Given this list of marker genes FBXO3, GPT2 (NCBI Gene Id 84706), SLFN12L, PIGN, INO80 (INO80 complex ATPase subunit), CHST15, ERCC6L2, CHORDC1, ZBTB21 (zinc finger and BTB domain containing 21), PCGF5, LACC1, ATP8B4, SATB1 (SATB homeobox 1), PHLDA3, PPP4R3B (NCBI Gene Id 57223), IL34, ODR4, NLK, SMARCA5, C5orf63, B3GNT2, C1orf74, ZXDB, EPS15L1, UBE2T, OXNAD1, PMS1, TMEM41B, CD69, CEBPB, SLC19A2, OSGEPL1, TMEM62, ZFAND3, TRMT10A, CRTAM, ZFP62, KCNQ5, REV3L, CKLF, RGS3, KLHDC2, ULK2, NOL8, TGIF2 (NCBI Gene Id 60436), GINM1 (NCBI Gene Id 116254), OGFOD1, MYH7, CEP162, AEN, SYNJ2, RBBP8, IL15RA, BDP1, CRABP2, SNAPC1, RNF19A, CEBPZOS, RPRD2, LANCL3, CCNG1, PURB, QRICH1, ITIH4, TIMM17B, SOS2, EEA1, MFSD6, ZNF426 (NCBI Gene Id 79088), IFNG, GTF3C6, MFF (NCBI Gene Id 56947), NFKBIE, NSUN6 (NCBI Gene Id 221078), UTP20, RBPMS2, ITIH3, CDKN1A, CCSER2 (NCBI Gene Id 54462), PRAMEF8 (NCBI Gene Id 729516), POLK, APPBP2, SLC6A2, FBXO22, PWP1 (PWP1 homolog, endonuclein), CHAC1, IFIH1, PIP5K1A, TRAPPC2B, TUSC1, JAK2, USP16, SIK3, GADD45B, CRAMP1, SDF2, UBXN2A, NUP54, PDLIM5, CHKA, SRP54, UBA3, RBM5, PARS2, BCL2A1, SLC7A3, RNFT1, TTC19, TFB1M, BLTP1, COQ10B, NEK1, TLCD1, CASP4, DDIAS, R3HDM2, TNFSF8, MRPL9 (NCBI Gene Id 65005), BTLA, BCLAF3, IARS1, RER1, CFLAR, DDX4, ATP6V1D, CAMLG, SLC7A1, CEP43, IL13, GPCPD1, GOSR1, ZNF322, EML1, UQCC3, TAGAP, EGR1, MYD88, FASLG, BCL10, ZDHHC13, WDHD1, CLIC4, RGS2, ZNF775 (NCBI Gene Id 285971), ASNS, POU2AF1, PEX7, NAGLU, ACTN1, TYW5, STAT4, GOLGB1, NOS3, SH3KBP1, TAF13, ATXN1, FAM241A, SNX9, MYH10, SF3B4, CENPQ, CDK17, ARAP2, GFI1, BHLHE40, PDE3B, DNAAF4, TEX15, TXNL4B, PON2, RPS27, TMEM184C, ATP6V0C, PSPH, ZDHHC6, FAM220A, METTL6, RAB6A, AMZ1, EDN1, IL2, COX15, GFOD1, EIF4EBP1, SCN4B, SCAF8, GBF1, NAB1, ABTB2, NFKBIL1, SNX32, TMEM167A, TATDN1, SAYSD1, ZNF330, SAT1, MTRR, SIRT3, TRIB3, GLS, here is a description of the gene set: Genes down-regulated in neuron cell line treated with interferon alpha for 12h: immature versus mature. Human neuronal differentiation alters responsiveness to innate immune stimuli and virus infections. We used microarrays to examine the transcriptional responses of the human BE(2)-C neuroblastoma cell line to retinoic acid-induced differentiation and type I IFN stimulation. from publication Peltier DC, Simms A, Farmer JR, Miller DJ (PMID 20483728) Human Gene Set: GSE16450_IMMATURE_VS_MATURE_NEURON_CELL_LINE_12H_IFNA_STIM_DN species: Homo sapiens